Given this list of marker genes ZC3H8, MYBBP1A, DHX36, ICE1, ZNF345, ERCC6, POLR3G, MYO1C, POLR3F, CHD8, POLR3C, RPTOR, MTOR, PRDX5, BAZ1B, NAB2, TENM1, BRF2, SETD5, DDX21, DEK, SF3B1, INHBA, ZNF76, MAF1, SMARCA5, ELL (elongation factor for RNA polymerase II), ZNF143, AR, ICE2 (NCBI Gene Id 79664), here is a description of the gene set: studied in species Homo sapiens Any process that modulates the frequency, rate or extent of transcription mediated by RNA ploymerase III. Human Gene Set: GOBP_REGULATION_OF_TRANSCRIPTION_BY_RNA_POLYMERASE_III